The following is a description of a gene set: Catalysis of the reaction: adenosine + H2O = inosine + NH3, in a double-stranded RNA molecule. studied in species Homo sapiens Human Gene Set: GOMF_DOUBLE_STRANDED_RNA_ADENOSINE_DEAMINASE_ACTIVITY, and this is the list of marker genes: ADARB2, ADAR, ADAD1, ZBP1, ADAD2, ADARB1